The following is a description of a gene set: species: Homo sapiens Human Gene Set: HNF4_Q6 Genes having at least one occurrence of the motif AARGTCCAN in the regions spanning 4 kb centered on their transcription starting sites. This matches the HNF4A transcription factor binding site V$HNF4_Q6 (v7.4 TRANSFAC)., and this is the list of marker genes: PICALM, RRM1, SEC16B, EVX1, FOXG1, MEIS2, ENPP6, KIFC3, SLPI, CDKL5, PROX1, SESN3, NFE2, PRKACB, ZNF513, SP140, CACUL1, PPCDC, ILVBL, WNK4, FAM91A1, GGNBP2 (gametogenetin binding protein 2), ABCA6, FUT2, SPRY1, RNF5, SULT2B1, SLN, SLC25A14, PRR14L, NPNT, SLC25A5, TSHZ3, BOD1L2, ZBTB8OS, CCER1, CAB39L, XPNPEP2, ELF4, SOWAHC, AQP3, C11orf52, TIPRL (TOR signaling pathway regulator), KRT35, KIF1C, TLE1, NOSTRIN, SLC35G3, RNF40, HBEGF, ABCF2, TIMM10B, RBM24, LYRM1, C1orf210, TRAPPC8, BMF, ORAI3 (ORAI calcium release-activated calcium modulator 3), C1S, AGR3, TAGLN2, H2AX, PPP1R13B (NCBI Gene Id 23368), ERGIC3, FOXP2, SPINT1, PAK1, TMA7, XK, ARHGEF2, TMEM88, TRPS1, RSPRY1, RND1, PHF21A, KMT2A, MRPL2, IER5L, CBX7, FBXW4, GPX2, SP7, YY1AP1, LAD1, PRDM1, RNF17, NIPBL, TMBIM1, DAP3, MID1, HNF1A, ART3, DUSP3, AGPAT1, SFRP2, ITGA5, GPD1, MTMR4, CCN2, EMX1 (NCBI Gene Id 2016), TM6SF2, MXD4, INCA1, ARFIP2, GAMT, SLC35G5, IMPDH1, KIAA0040, SLC41A2, METRN, AGO1, RARA, KRT24, ASB2, USH1C, ABCA12 (NCBI Gene Id 3392), ERBB3, PLA2G12B, PURA (NCBI Gene Id 5813), PSME3IP1, WIPI1, DYRK1A, NHERF1, PDZK1, EDEM1, FUT11, TUBA1C, SEMA3B, C8A, MAN1A1, MMP16, ADM, SERPIND1, ENOX2, KLC4, KIRREL3-AS3, KCTD12, NLK, NR5A2, TRIM15, INSR, RINT1, RBFOX2, PCDHGC3 (protocadherin gamma subfamily C, 3), SEPTIN10, GLYAT, XRCC5, SP8, GRHL2, CGN, SMAD6, CFB, MCU, KANSL1, MAP2K6, GRIA3, EBF2, LMO3, HPCA, UCK2, EXOSC7 (NCBI Gene Id 23016), TTC27, CACNA2D3, C4A, TSKU, DACT2, CLN5, SPEM2, GRB7, AGXT2, SLC7A8, PART1, PLEKHG6 (pleckstrin homology and RhoGEF domain containing G6), HOXA11, DNAJC22, PTMS, CREB3L2, PANX2, RALY, C9 (NCBI Gene Id 12279), HOXA5, MTTP, AGMAT, PTPRH, HTN1, MISP, PROS1, SLC26A10P, HOMEZ, NRG2, MIR600HG, HOXA10, RARB, HOXA3, CCDC136, PELO, LUZP1, CLDN15, SH2D6, FBXW7, TM4SF20, SLC39A14, HNRNPA0, CTDSPL2, GIPC2, ZIC2 (NCBI Gene Id 7546), HJV, ZNF32, SLC22A7, WNT3, SLC16A4, GBA2, COL25A1, SUSD2, PIK3R3, FOXA1, ARHGEF37, C4B, GATA4, FOXO1, IPO4, CPLX2 (NCBI Gene Id 84242), APC, EFNB1, ITGA3, KIRREL3, GTPBP1, EMP1 (NCBI Gene Id 2012), MAGED1, KAT5, AJUBA, PLS1, CCNB2, MLEC, XRCC6, MOBP, ID2, NAV2, CCDC51, RAB1A, RASSF5, ZNF3, TGFB1, JMJD1C, TMEM150A, RAB3D, TLK2, PKLR, LRRC17, HOXB7, PCDH17, ATF4, CACNB2, SLC5A2, NUMB, ZDHHC3, LCAT, CCDC85B, ITGA1, PIPOX, TREH, FKBP2, SCAF4, ATAD5, HEPACAM2, DZIP1L, ETV1, TRAF3, EMX2, RASAL2, LHX1